Given this list of marker genes Trem3, Cd6, Trem2, Nlrp6 (NCBI Gene Id 101613), Tlr2, Cd14, Lbp, Dmbt1, here is a description of the gene set: Binding to lipoteichoic acid. Mouse Gene Set: GOMF_LIPOTEICHOIC_ACID_BINDING studied in species Mus musculus